The following is a description of a gene set: species: Mus musculus Aberrant expression of the human homeobox-containing proto-oncogene TLX1/HOX11 inhibits hematopoietic differentiation programs in a number of murine model systems. Here, we report the establishment of a murine erythroid progenitor cell line, iEBHX1S-4, developmentally arrested by regulatable TLX1 expression. Extinction of TLX1 expression released the iEBHX1S-4 differentiation block, allowing erythropoietin-dependent acquisition of erythroid markers and hemoglobin synthesis. Coordinated activation of erythroid transcriptional networks integrated by the acetyltransferase co-activator CREB-binding protein (CBP) was suggested by bioinformatic analysis of the upstream regulatory regions of several conditionally induced iEBHX1S-4 gene sets. In accord with this notion, CBP-associated acetylation of GATA-1, an essential regulator of erythroid differentiation, increased concomitantly with TLX1 downregulation. Coimmunoprecipitation experiments and glutathione-S-transferase pull-down assays revealed that TLX1 directly binds to CBP, and confocal laser microscopy demonstrated that the two proteins partially colocalize at intranuclear sites in iEBHX1S-4 cells. Notably, the distribution of CBP in conditionally blocked iEBHX1S-4 cells partially overlapped with chromatin marked by a repressive histone methylation pattern, and downregulation of TLX1 coincided with exit of CBP from these heterochromatic regions. Thus, we propose that TLX1-mediated differentiation arrest may be achieved in part through a mechanism that involves redirection of CBP and/or its sequestration in repressive chromatin domains. Selected gradually up-regulated genes whose expression profile follows that of HBZ in the TLX1 Tet On iEBHX15-4 cells (pro-erythroblasts). from publication Riz I, Akimov SS, Eaker SS, Baxter KK, Lee HJ, Mariño-Ramírez L, Landsman D, Hawley TS, Hawley RG (PMID 17213805) Human Gene Set: RIZ_ERYTHROID_DIFFERENTIATION_HBZ, and this is the list of marker genes: POU3F3 (POU class 3 homeobox 3), NKX2-5, TBX2, FOSB, TAL2, EYA2, SIX2, CBX7, GATA5, PAPOLA, HOXB13, CUX1, AFF1, TMPO, CBX3, TFAP2C, ETAA1, MPL, BARD1, HMGB1, ZNF436, MCM5, MCM7, BASP1, KDM5A, NR2F1, SOX1, NR4A2, SOX18, NR5A1, MCM4, E2F8, POU2F3, POU3F2, SOX4, GCM2, PROX1 (prospero homeobox 1)